Given this list of marker genes Pax1, Cacna1g, Col2a1, Tinagl1, Perp, Mcpt8, Gzme, Parm1, H4c1, Nnat, Snca, Foxa1, Thsd4, Nrn1, Ppp1r3c, Acot1, Rgs4, Tnfrsf11b, Chodl, Clu, Sema4f, Clca3a1, Plscr2, Wnt5b, Gna14, Rgs5, Kcna5, Shroom3, Kcnmb4, Mpped2, Tex15, here is a description of the gene set: from publication Plasari G, Calabrese A, Dusserre Y, Gronostajski RM, McNair A, Michalik L, Mermod N (PMID 19752192) species: Mus musculus Mouse Gene Set: PLASARI_NFIC_TARGETS_BASAL_UP Genes up-regulated in MEF cells (embryonic fibroblast) upon knockout of NFIC. Transforming growth factor beta (TGF-beta) and platelet-derived growth factor A (PDGFAlpha) play a central role in tissue morphogenesis and repair, but their interplay remain poorly understood. The nuclear factor I C (NFI-C) transcription factor has been implicated in TGF-beta signaling, extracellular matrix deposition, and skin appendage pathologies, but a potential role in skin morphogenesis or healing had not been assessed. To evaluate this possibility, we performed a global gene expression analysis in NFI-C(-/-) and wild-type embryonic primary murine fibroblasts. This indicated that NFI-C acts mostly to repress gene expression in response to TGF-beta1. Misregulated genes were prominently overrepresented by regulators of connective tissue inflammation and repair. In vivo skin healing revealed a faster inflammatory stage and wound closure in NFI-C(-/-) mice. Expression of PDGFA and PDGF-receptor alpha were increased in wounds of NFI-C(-/-) mice, explaining the early recruitment of macrophages and fibroblasts. Differentiation of fibroblasts to contractile myofibroblasts was also elevated, providing a rationale for faster wound closure. Taken together with the role of TGF-beta in myofibroblast differentiation, our results imply a central role of NFI-C in the interplay of the two signaling pathways and in regulation of the progression of tissue regeneration.